The following is a description of a gene set: studied in species Homo sapiens Human Gene Set: PULVER_FOREY_PERTURB_ACCUMULATION_M_EG1 Genes whose depletion leads to accumulation of cells in M/eG1 (pVal < 0.05) in K562 Repogle et al., 2022 reanalyzed with Velocycle from Lederer et al., 2024 Transcription regulation during the cell cycle is crucial for ensuring genes are expressed at the right time and in the correct amounts, coordinating key processes like DNA replication, mitosis, and cell division. In our study,, and this is the list of marker genes: NUP188, ZFP57, PWWP2A, PLIN3, MAPK1IP1L, RTN3, CCDC116, ZNF536, INSM2, FBRSL1, ZNF366, UBN1, CCDC18, TUBA1C, UBE2K, ATR, SORD, CCDC144NL, PLEKHF1, STT3A, DYNC1I2, SRSF7, CTPS2, SLC30A5, ANGPT1, PHRF1, LSM3, TNIP1, TMEM147, ZNF221, PIGU, PDCD2L (NCBI Gene Id 84306), RNF113A, ACTR1B, HCFC1R1, MCM5, TYW1, ZSWIM8, RARA, ZNF233, ARMC1, ODF2, SCAF4, DOK1, DDX5, EDEM2, SMG1, TIMELESS, CCDC167, NELFCD, WDR11, RAD51C, TOMM6, RBM39, ZNF746, NAGA, PPHLN1, TICRR, ZNF418, NR1D1, DBF4, FOXL1, H2AC1, PAXIP1, BRMS1L, BAD, ZNF565, FAM229B, ESX1 (NCBI Gene Id 80712), EPHX1, DYNC2I2, COP1, BCL2L11, GTF2F2, ANKLE2, BRD1, NRDE2, ATOH8, ENOPH1, SRBD1, YY1, SNX9, TAF9, ATF3, CHCHD2, DR1, SPAG9, UBE2D2, SYNJ2, CYBRD1, CDCA7, CCDC174, YBX2, UBE4A, UHMK1, ZNF671 (zinc finger protein 671), KRCC1, USP49 (NCBI Gene Id 25862), PFKFB2, URB1, SNAP29, NDC1, GPATCH1, SF3B4, TFAP2E, RAB28, FRA10AC1, BCKDK, ZNF728, PUF60, SLC37A1, SDF4, NUP85, RTCA, POM121C, TRIM58, FKBP1A, ATRIP, GMPR2, HUS1, LMAN1 (NCBI Gene Id 3998), DCTN4, HPF1, BARX1, DDX49, TSPAN14, ZNF524, SAR1B, LYRM1, TBCE, TNRC6A, TNFAIP8, DCTN3, PRDM5, PASD1, CARM1, ZNF200, PIP4K2B, LACTB, SLC12A5, NSRP1, POC1B, NEK7, MCU, CAPZB, ADAT1, OLFML3, DCAF7, CENPE, GMPPB, CDC42SE2, CEP78, TRIM44, FAM83D, SPATC1L, FOXN1, SCML4, AGPS, SH3GL1, FBXO45, GGA1, MCM3, MFGE8, DSCR4, NUCKS1, KLHL17 (NCBI Gene Id 339451), RNF41, ONECUT3, AAK1, MARS1, ZFYVE21, PEX2, PIF1, ZNF664, DONSON, DCTN2, RNF115, PNPLA4, CTSL (cathepsin L), GEMIN6, RPP25L (ribonuclease P/MRP subunit p25 like), ZNF446, ETV6, NCOA5, AFF4, CDK12, CREB3L4, TXNRD2, ZFHX3, NOL12, CCDC97, ZDHHC24, ZNF217, AP2A2, RCN1, ZNHIT2, NKAP, PBX1, PSMA1, AUP1, RAB27A, TPST2, DYNC1H1, U2SURP, ORC2, ZNF99, ICE1, ZNF773, DENND10, RHOXF2, RNF103, DAG1, UBIAD1, CD164, ASCC2, SNRNP25, FKBP14, KLHL20, TTC31, ZNF7, PHYHD1 (phytanoyl-CoA dioxygenase domain containing 1), ATAD2, CCNL1 (cyclin L1), PSMG3, NHLRC3, AMMECR1, FOXC1, NR0B1 (NCBI Gene Id 8238), NAA16, RUVBL1, SPDL1, WWP1, ALKBH4, TNPO3, GPKOW, POLR2I, DHX16, RRP36, CWC15, SNRPE, APRT, MRPL46, TMEM134, GNB4, KLF2, ALDH5A1, CFDP1, SSNA1, SURF4, CBS, BCL2L1, HINT1, SERHL2 (serine hydrolase like 2), PMM2, OTP, ZNF83, FKBP3, KLHDC3 (NCBI Gene Id 116138), KCMF1, TMEM164, UQCC1, FAM217B, YJEFN3 (YjeF N-terminal domain containing 3), RAD51, ACTR10, GPD2, ZNF326, BLTP3B, NLN, IPO4, FOXD4L1, RCC1L, APOO, NBN, MIPOL1, USP40, LIN37 (lin-37 DREAM MuvB core complex component), FBXW7, POC1A (POC1 centriolar protein A), TIMM50, ZUP1, COBL, ALDH4A1, ILKAP (NCBI Gene Id 9345), RBM3, NUP93, TALDO1, H1-10, RPUSD1, ZNF880, SCARB2, SAMHD1, PPIL4, CLPP, ZNF595, ZNF662, TBCB, TMEM185B, PABPC4, KIFC1, ZBTB1 (NCBI Gene Id 22890), KIAA0513, PPP3CA, PHF3, RXRG, PITPNB